Given this list of marker genes MTCH2, EMC6, EMC8, TIMM10, EMC3, EMC4, COX18, TIMM9, EMC2, EMC7, MMGT1, EMC9, GET3, EMC1, OXA1L, MTCH1, EMC10, here is a description of the gene set: Binds transmembrane domain-containing proteins and mediates their integration into a membrane. species: Homo sapiens Human Gene Set: GOMF_MEMBRANE_INSERTASE_ACTIVITY